The following is a description of a gene set: Any process that stops, prevents, or reduces the frequency, rate, or extent of production of transforming growth factor-beta1. species: Mus musculus Mouse Gene Set: GOBP_NEGATIVE_REGULATION_OF_TRANSFORMING_GROWTH_FACTOR_BETA1_PRODUCTION, and this is the list of marker genes: Furin, Tsku (tsukushi, small leucine rich proteoglycan), Tyrobp, Laptm4b, Cd2ap, Gata6